The following is a description of a gene set: A plasma membrane region adjacent to the base of eukaryotic cilia and flagella that is enriched in endocytosis-associated proteins and vesicles and that appears to regulate ciliary membrane homeostasis. studied in species Mus musculus Mouse Gene Set: GOCC_PERICILIARY_MEMBRANE_COMPARTMENT, and this is the list of marker genes: Adgrv1, Kif17, Rp2, Ush2a, Kifap3, Whrn